The following is a description of a gene set: studied in species Homo sapiens Any signaling pathway that modulates the activity of a cell cycle cyclin-dependent protein kinase to modulate the switch from G2 phase to MI phase of the meiotic cell cycle. Human Gene Set: GOBP_REGULATION_OF_G2_MI_TRANSITION_OF_MEIOTIC_CELL_CYCLE, and this is the list of marker genes: CDC25C, CDC25B, STK35, PKMYT1, CDC25A, PDIK1L, USP17L2